The following is a description of a gene set: GRB2 events in ERBB2 signaling Human Gene Set: REACTOME_GRB2_EVENTS_IN_ERBB2_SIGNALING species: Homo sapiens, and this is the list of marker genes: EGF (epidermal growth factor), NRG2, BTC (betacellulin), NRG3, NRG1 (NCBI Gene Id 653104), ERBB4, NRAS, HRAS, EGFR, KRAS, EREG, NRG4, HBEGF, GRB2, ERBB2, SOS1